The following is a description of a gene set: species: Homo sapiens Human Gene Set: GOBP_INTRACELLULAR_COPPER_ION_HOMEOSTASIS A homeostatic process involved in the maintenance of a steady state level of copper ions within a cell., and this is the list of marker genes: MT2A, ARF1, SLC31A2, ATP7A, CP, SCO2, ANKRD9, SLC31A1, COX19, APP, ATOX1, PRNP, PRND, CCDC22, ABCB6, SLC30A10, SCO1, ATP7B